Given this list of marker genes IDUA, GUSB, ARSB, ARSK, IDS, here is a description of the gene set: Human Gene Set: HP_DERMATAN_SULFATE_EXCRETION_IN_URINE Dermatan sulfate excretion in urine species: Homo sapiens An increased concentration of dermatan sulfate in the urine.